The following is a description of a gene set: The chemical reactions and pathways involving a polysaccharide, a polymer of many (typically more than 10) monosaccharide residues linked glycosidically. Mouse Gene Set: GOBP_POLYSACCHARIDE_METABOLIC_PROCESS studied in species Mus musculus, and this is the list of marker genes: Igf2, Atg3, Tgfb1, Enpp1, Phlda2 (NCBI Gene Id 22113), Gcgr (glucagon receptor), Khk, Slc37a4, Egf, Sorbs1, Stk40, Wdr45, Epm2a, Lepr (NCBI Gene Id 16847), Comt, G6pc1, Ppp1r2, Ppp1cc, Gaa, Ppp1r1a, Ap2a1, Phkb, Adrb1, Ndst1, Pomc, Gnmt, Has3, Ppp1r3b, Ext1, Gck, Hmgb1, Has1, Irs2, Per2 (NCBI Gene Id 18627), Mtor, Ins1, Pgm1, Ptger4, Atg12, Ppp1r3g, Ppp1r3e, Pdgfb, Ppp1cb, Wipi1, Pgf, Tcf7l2, Epm2aip1, Rubcnl, Prkag3, Il6st, Chia1, Gabarapl1 (GABA type A receptor associated protein like 1), Ppp1r3f (NCBI Gene Id 54646), Nr1d1, Irs1, Igf1, Ptges3, Rb1cc1, Galnt3, Inpp5k, Adra1b, Gys2 (NCBI Gene Id 232493), Chil3, Atg2a (NCBI Gene Id 69041), Pfkm, Gsk3a, Ugp2, Pygm, 1810024B03Rik, Prkag2, Npc1, Fut9 (NCBI Gene Id 14348), Gyg1, Gys1, Cltc, Phkg1, Grb10, Pygb, Has2, Agl, Mgam, Chit1, Esrrb, Nhlrc1, Akt1, Gsk3b, Dyrk2, Ext2, Ppp1r3d, Phkg2, Pth, Nfkb1, Wipi2, Blvra, Stbd1, Pcdh12, Ins2, Smpd3, Phka1, Adcy10, Gfpt1, Ppp1ca, Wdr45b, Ppp1r3c, Acadm, Pask, Pgm2, Atg2b, Ppp1r3a, Pygl, Gbe1, Insr, C1qtnf2, Akt2, Phka2